Given this list of marker genes Lig4, H2bc6, Nhej1, H2bc11, Pias4, Xrcc6, H2ax, H2bc14 (H2B clustered histone 14), Babam1, H4c6, H2bc23, H4c16, Mre11a (NCBI Gene Id 17535), H2bc1, Herc2 (HECT and RLD domain containing E3 ubiquitin protein ligase 2), Xrcc4, H4c2, Mdc1, Babam2, H2bc8, H4c4, Nsd2, H2bc22, Prkdc, H4c1, H2bc13, Abraxas1, H2bc3, Nbn, Tdp2, H4c9, H2bc7, Tdp1, H2bc15, H4c3, Rnf8, Uimc1, Polm, Brcc3, Atm, H3f4, H2bc12, Xrcc5, Rad50, Ube2n (ubiquitin-conjugating enzyme E2N), H2bc26, Rnf168, H2bc21, Poll, H4c14, Ube2v2, H4c11, Paxip1, H4c17, H2bc4, Rif1, H4c12, H4c8, Dclre1c, Brca1, Kat5, H4c18, Bard1, H2bc24 (NCBI Gene Id 671645), H2bc9, Trp53bp1, here is a description of the gene set: studied in species Mus musculus Mouse Gene Set: REACTOME_NONHOMOLOGOUS_END_JOINING_NHEJ Nonhomologous End-Joining (NHEJ)